The following is a description of a gene set: species: Homo sapiens Transport of connexons to the plasma membrane Human Gene Set: REACTOME_TRANSPORT_OF_CONNEXONS_TO_THE_PLASMA_MEMBRANE, and this is the list of marker genes: GJA1, TUBB8B, TUBB8, TUBA3C, TUBA1C, TUBAL3, TUBB2A, TUBB2B, TUBB4B, TUBA1A, TUBB6, TUBA8, TUBB4A, TUBA4A, TUBB3, TUBA4B, TUBB1, TUBA3D, TUBA3E, TUBA1B, GJB2